The following is a description of a gene set: species: Homo sapiens Human Gene Set: HP_VENTRICULAR_ESCAPE_RHYTHM A ventricular escape rhythm occurs whenever higher-lever pacemakers in AV junction or sinus node fail to control ventricular activation. Escape rate is usually 20-40 bpm, often associated with broad QRS complexes (at least 120 ms). Ventricular escape rhythm, and this is the list of marker genes: SYNE2, GJA5, LMNA, FHL1, SCN5A, SGO1, GNB5, TMEM43, SYNE1, NPPA (natriuretic peptide A), EMD